The following is a description of a gene set: Mouse Gene Set: PARP1_TARGET_GENES studied in species Mus musculus Genes containing one or more binding sites for (Parp1) in their promoter regions (TSS -1000,+100 bp) as identified by GTRD version 20.06 ChIP-seq harmonization. from publication Yevshin I, Sharipov R, Kolmykov S, Kondrakhin Y, Kolpakov F (PMID 30445619), and this is the list of marker genes: Nup205, Nudt21, Srrm3, Ppp1r18, Dipk2a, Bad (BCL2-associated agonist of cell death), Chrnb2, Rpl39, Snx15, Def8, Ccnf, Cc2d1a, Pgbd5, Cep41, Gclm, Tbkbp1, Hagh, Lck, Iscu, Mir7b, Vps9d1, Ntmt1, Alg9 (NCBI Gene Id 77986), Bmp1, Cacng2, Cc2d1b, Nradd, Large1, 1700105P06Rik, Mapk11, Tmem198 (NCBI Gene Id 319998), Ogdhl, Mbd5, Rnaseh2a, Cd109, Otub1, Pkd2l2, 6330562C20Rik, Narf, Odf2l, Srpra, Sfxn3, 6030458C11Rik, Atp5f1c, Papss1, Hmces, Fscn1, Emx2, Zfp963, Meis3, Ginm1, Sfi1, Hrh3, Cntnap1, Cyb5r4, Src, Bdnf, Zc3h11a, Dnm1l, Scg2, Prpf4, Fancb, Ambra1, Nppb, Gm11592, Psmc3, Synj2, Glra1, Mob1a, Grin1 (NCBI Gene Id 14810), Fis1, Hspa12a, Hpca, Foxred1, Zfp763, Sart3, Lrrc24, Dazap1, Ttc39d, Tug1, Cyp51, Tpbg (NCBI Gene Id 264331), Mrpl58, Ptma, Ezr, Rbis, Ctxn2, Tmem94, Pdpr (NCBI Gene Id 319518), Ppp1r18os, Zzz3, Aatf (apoptosis antagonizing transcription factor), Hnrnpk, Lhx3, Tsr3, Nbea, Hspa8, Mapk8ip2, Kat5, Scamp5, Chpf, Set, Dynll1, Kctd5, D330041H03Rik, Gm16845, Tceanc2, Arl14ep, Mzt2, Cmc2, Cux1, Zfp276, Disp2, 4933427D14Rik, 2610020C07Rik, Arfgap2, Diablo, Mterf3, Zfp334, Asphd1, Fgfrl1, Gpr137, Abhd4, Elovl1, Aco2, Smpd3, Sharpin, Drosha, Cwc22, Tln1, Pdzd7, Lmna, Gtpbp8, 2500002B13Rik, Ctbp1, Msmo1, 1500002F19Rik, Bop1, Jagn1, Tmem59, Ube2i, Gm23639, Trp53bp1, Cul4a, Ccdc142os, Phf5a, Tsc2, Strada, Nr2c2, Ldlrad3, Epb41l4aos, Gm10548, Ubc, Maf1, Orc6, Rex1bd, Zfp105, Gna11 (NCBI Gene Id 327779), Zswim8, Tmbim6, Aco1, Ppil4, Fbll1, Zdhhc24, Kif11, Vgf, Pank2, Otud4, Rmi1, 1700086O06Rik, Hexim1, Brme1, Sez6l2, Col4a1 (NCBI Gene Id 207132), Eef2kmt, Dst, Usp3, H3f3a, Zfp68, Npdc1, Plekhh3, Prdx2, Olfm3 (olfactomedin 3), Dcun1d2, B130034C11Rik (RIKEN cDNA B130034C11 gene), Gm26590, Txnrd1, Fam216a, Mtdh, Mapk1ip1l, Cenpn, Srrt (NCBI Gene Id 83701), Cplx3, Eaf2, Clip1, Marchf4, Arfrp1, AA914427, Actn3, Zbtb48, Klc2, Rps6ka2, Ahcyl1, Pknox2, Atp6v1b2, Gm16838, Dad1, Nrxn2, Sap30, Rab3c, Krt86, Lats1, Nefm (NCBI Gene Id 18040), Cdc23, Usb1, 4933434E20Rik, 0610009E02Rik, Dap3, Fbxw4, Oxct1as, Gm19391, Arl5b, Gm13778, Miga2, AA474408, Loxl1, Ccdc92b, Cand1, Lamb1, Cfap68, Rsl1d1, Pard3, Gpn3, Thap6, Rbm27, Rps6ka1, Adam9, Rundc3a, Gm10010, Gamt, Rchy1, Gm10382, Scamp2, Cdk4, Nuak1, Zbed6